Given this list of marker genes EMC3, EMC6, EMC9, MMGT1, EMC2, EMC10, EMC8, EMC1 (NCBI Gene Id 23065), EMC7, WNK1, EMC4, here is a description of the gene set: A process of protein insertion into the endoplasmic reticulum (ER) membrane in which stop-transfer membrane-anchor sequences become an ER membrane spanning helix. species: Homo sapiens Human Gene Set: GOBP_PROTEIN_INSERTION_INTO_ER_MEMBRANE_BY_STOP_TRANSFER_MEMBRANE_ANCHOR_SEQUENCE